The following is a description of a gene set: human blood monocytes were isolated, activated and harvested at several timepoints In this study, we identified genes that were differentially expressed in human monocytes activated with eiter NOD2L and/or TLR2/1L. species: Homo sapiens Genes down-regulated in monocytes (24h): M. tuberculosis 19 kDa lipopeptide versus M. tuberculosis 19 kDa lipopeptide and muramyl dipeptide. Human Gene Set: GSE34156_TLR1_TLR2_LIGAND_VS_NOD2_AND_TLR1_TLR2_LIGAND_24H_TREATED_MONOCYTE_DN from publication Schenk M, Krutzik SR, Sieling PA, Lee DJ, Teles RM, Ochoa MT, Komisopoulou E, Sarno EN, Rea TH, Graeber TG, Kim S, Cheng G, Modlin RL (PMID 22447076), and this is the list of marker genes: ARHGAP24, MRLN, FGF18, CD44, DMBT1, TMEM161B, HOXD12, TLE5, GLA, C3orf62, DIAPH1, CCKBR, AP1S3, ACAD10, TLCD1, SOAT2, WDR44, RASD2, POMGNT1, TPPP3, ZNF551, CLNS1A, EVI5, LOXL3, CDR2, DNAJB6, HOXA4, YWHAZ, RPL23A, FAM120A, TMED7, IER3 (immediate early response 3), LMLN, SLFN12, HIVEP2, OPRD1, CSNK2A2, POSTN, ANK2, MICALL2, TRAPPC2, PPP1R14A, TRMO, ZNF124, ASB7, C1orf198, CNN1, PLEKHA2, TTC23L, KRT25, OCSTAMP, PRLR, CYP27A1, GTPBP4, ATXN7L1 (ataxin 7 like 1), RNF7, F13B, ZNF708, LONRF3, AK8, THRB, ANAPC4, ADGRL4, TEX48, ARHGEF11, TSG101, CCND2, RTL8B (NCBI Gene Id 441518), PPP2R5D, ALB, PXYLP1, SLC29A2, ARID1B, SET (SET nuclear proto-oncogene), IRS2, GPR39, CNBP, FAM13C, EID3, BBS7, FAM3C, IFT74, CBY1, SPINDOC, STMN2, API5, DCAF12, SERPIND1, CELA2A, FAM168A, RNF157, SFRP5, NLRP5, SERPINC1, KICS2, TAF1A, FOSL1, GFM1, CAMKMT, TMEM214, SPSB4, CHP2, PAQR3, LRATD1, SQOR, LDAF1, DEPDC1, C5orf63, USP50, CCN2, PLPP7, JUND, CASQ2, SMARCA1, LACTBL1, UCP1, UBLCP1, MTF1, MBD2, LRRC14, GPR34 (G protein-coupled receptor 34), FCF1, SOS2, CYTIP, DHDDS, RASAL2 (NCBI Gene Id 9462), EVX2, KIAA1549L, RGS18, PCGF5, TLR2, GADD45B, EMC1, KCNG1 (NCBI Gene Id 9035), ZNF697, RBMXL2, ANAPC10 (anaphase promoting complex subunit 10), PRDX1, SUGT1, KRTDAP, ARHGEF16, ARNT, CALCB, GABRG2, PIP4K2A, RAB22A, PRCP, RELL1, BBLN, KRTAP19-5, PLPP2, EPS8L1, NR2E1, PEX10, NRG1, DGKB, USP27X, BCL6, LNPK, PBX1, CCDC70, BRIP1, NOL7, TTLL9, STAT3 (NCBI Gene Id 6774), SSB, ZMYND15, LIX1, LIPE, CTSH, STARD5, BPNT2, PRKDC, MIB1, RAD23A (RAD23 homolog A, nucleotide excision repair protein), TLE1, SLC22A12, USP54, SCN3B (sodium voltage-gated channel beta subunit 3), KANSL1L, BLCAP, ARL6, MIS12, RIC1, BAMBI, SYT4, EAF2, BRD2, RGS2, B3GALNT1, PFAS, KIF17 (NCBI Gene Id 57576), GCNT1, IL6, DKK2, XPNPEP3, HLA-DRB1, KHDRBS3, CACHD1, PDCD1